The following is a description of a gene set: Any process in which membrane rafts are transported to, or maintained in, a specific location. Membrane rafts are small (10-200 nm), heterogeneous, highly dynamic, sterol- and sphingolipid-enriched membrane domains that compartmentalize cellular processes. Human Gene Set: GOBP_MEMBRANE_RAFT_LOCALIZATION species: Homo sapiens, and this is the list of marker genes: NAXE, PTPRC, CD2, DOCK2, MAL, LAT, GSN, RALA, YJEFN3